Given this list of marker genes Ifi44, Zc3hav1, Adar, Arf1, Gbf1, Flt3, Gsdme, Ccl19-ps6, Ext1, Pou2af1, Ddx3x, Cxcl10, Irgm2, Ifi44l, Igtp, Ikbke, Lgals8, Irgm1, Chuk, Ccl19-ps5, Tgfb1, Calr, Zc3h12a, Il12a, Ifnb1, D1Pas1, Ccl19-ps1, Gli2, Gm11772, Atf2, Il6, Penk, Mapk11, Ccl19-ps3, Nlrp3, Ifih1, Wdfy4, Mapk14, Lgals9, Mmp12, Pou2f2, Irf5, Hif1a, Nfkb1, Il21, Tlr3, Ccl5 (NCBI Gene Id 20304), Crebbp, Irf3 (NCBI Gene Id 54131), Tomm70a, Tlr7, Riok3, Ccl19, Fmr1, Bax, Rrp1b, Ccl19-ps4, Smad3, Trim6, Vwce, Hsp90aa1, here is a description of the gene set: Mouse Gene Set: GOBP_CELLULAR_RESPONSE_TO_VIRUS species: Mus musculus Any process that results in a change in state or activity of a cell (in terms of movement, secretion, enzyme production, gene expression, etc.) as a result of a stimulus from a virus.